The following is a description of a gene set: Genes down-regulated in peripheral blood mononucleocytes by HGF compared to those regulated by CSF2RB (GM-CSF) and IL4. Several hematopoietic growth factors, including interleukin-10 (IL-10) and transforming growth factor-beta1 (TGF-beta1), promote the differentiation of tolerogenic dendritic cells (DCs). Hepatocyte growth factor (HGF) is a pleiotropic cytokine whose effects on human DC differentiation and function have not been investigated. Monocytes cultured with HGF (HGFMo) differentiated into accessory cells with DC-like morphology, released low amounts of IL-12p70 and up-regulated IL-10 both at the mRNA and at the protein level. Upon activation with HGFMo, allogeneic CD4+CD25- T cells expressed the T regulatory (Treg)-associated transcription factor FoxP3, proliferated poorly, and released high levels of IL-10. Interestingly, blockade of surface immunoglobulin-like transcript 3 (ILT3) on HGFMo or neutralization of secreted IL-10 translated into partial restoration of T-cell proliferation. Secondary stimulation of HGFMo-primed CD4+ T cells with immunogenic DCs differentiated with granulocyte-macrophage colony-stimulating factor (GM-CSF) and IL-4 from monocytes of the same donor resulted in measurable T-cell proliferation. HGFMo-primed CD4+ T cells significantly inhibited the proliferation of naive CD4+CD25- T cells in a cell-contact-dependent manner. Finally, DNA microarray analysis revealed a unique gene-expression profile of HGF-activated monocytes. Collectively, our findings point to a novel role for HGF in the regulation of monocyte/DC functions that might be exploited therapeutically. studied in species Homo sapiens from publication Rutella S, Bonanno G, Procoli A, Mariotti A, de Ritis DG, Curti A, Danese S, Pessina G, Pandolfi S, Natoni F, Di Febo A, Scambia G, Manfredini R, Salati S, Ferrari S, Pierelli L, Leone G, Lemoli RM (PMID 16527888) Human Gene Set: RUTELLA_RESPONSE_TO_HGF_VS_CSF2RB_AND_IL4_DN, and this is the list of marker genes: FCHSD2, PPP1R16B (NCBI Gene Id 26051), GLS, ACSL3, TRIP10, NCOA3, TBC1D13, TMEM131L, IL6ST, CCL22, PKNOX1, EGLN3, ANP32A, LMBR1L, MCM5, CRYZ, SUZ12, CD1B, CASP3, ZHX2, LRRK1, IER5 (NCBI Gene Id 51278), PLXNA1, BATF3, FNBP1, PTP4A3 (protein tyrosine phosphatase 4A3), NIT2, ZNF274, HOMER2, ADAM19, QPRT, FOXJ2, TRAF1, MICAL1, SERPINF1, CFP, KIF2A, NME3, NREP, SPINT2, CCL13, LDLR, TIA1, MAOA, LYPD3 (NCBI Gene Id 94931), HEBP2, ST3GAL6, CD59, GPR137B, ITGA4, SLC1A2, CSNK1E, ST8SIA1, CYTH1, NDE1, CCSER2 (coiled-coil serine rich protein 2), CCR7, RUNX3, ARGLU1, CYB5A, ATRX, SYF2, REPIN1, RNF138, NETO2, DUSP5, MAP3K6, ANXA2P2, C3orf18, ATP1B3, RNASE4, YWHAQ, ZFAND5, RAB38, ADAM8, FSCN1, RAB11FIP1, MOB1A, CCNL1, RPL22, SDC4, DIPK1A, SCN11A, MAP3K14, TNFAIP8, VDR, CD209, ARL6IP5 (ADP ribosylation factor like GTPase 6 interacting protein 5), LY75, IL1R1, CCNG2, IL1R2, CD58, PVR, SPRED2, HDAC2, MED14, GABBR1, HERPUD1, ANXA2, RFTN1, NET1 (NCBI Gene Id 10276, neuroepithelial cell transforming 1), RABGAP1, CXCR4, BCOR, CD83, CD80, F2RL1, JAG1, TCF3, SQLE, LTB4R, TBCB, NRG1, WNT5B, DHCR7, RPS4XP2, STK17B, PLPP1, MS4A6A, ELL3, CCNI, RASGRP2, MGLL, MREG, SYNGR3, PSD3, GFPT1, DUOX1, LMNB1, POGLUT1, ROBO1, NEK3 (NIMA related kinase 3), ADAM12, IRF4, IL13RA1, SETD1B, CDKN1A, EPB41L2, CEP350, TXN (thioredoxin), IL21R, PLAC8, INHBA, MMP12, CD1E, SFPQ, SON, ARHGAP22, ENSA, CSF2RA, TBC1D4, NIBAN1, SLC16A5 (solute carrier family 16 member 5), ZNF185, SMARCC1, DPYSL2, VCAN, TNIP2, RO60, ASMTL (acetylserotonin O-methyltransferase like), SGPL1, ICAM3 (NCBI Gene Id 3385), MIS18BP1, CLIC2, CCL17, SPOCK1, FCER1A, UBAP2L (NCBI Gene Id 9898), DEPTOR, IFITM3P7 (IFITM3 pseudogene 7), CEP83, SMS, SNHG32, SLAMF1, TRADD, GADD45B, PLEKHA5, NECTIN2, DNAJB6, TUBA1C, FKBP1B, CREBL2, RAMP1, CD86, DYNC1LI1 (dynein cytoplasmic 1 light intermediate chain 1), CREG1, CD84, TTN, TRAF5, HNRNPA1, ABCG1, MARCKSL1, CERS6, OPTN, MAP4K4, CFLAR, LITAF, CEP15, FZD5 (NCBI Gene Id 81561), ZFP36, NFATC2IP, BTG1, RASGRP3, PELI1, SEPHS1, CACNA2D3, TMEM97, SORL1, GRK3, MARCKS, MED13L, TNFRSF4, EBI3, PLGRKT, RUNX1, GRSF1, RGS2, RPL28, LPP, PPM1F, PHYH, MCL1, CCL19, EED, ARHGEF6, RAB8B, BET1, BIRC3, PSEN2, LAMP3, NR4A3, JAK1, PPP1R12A, N4BP1, CRIP1, HSPB1, CSRP1, ZDHHC18, RAB9A, CIRBP, DAPP1, NKTR, RAB3GAP1, CELF2, FILIP1L, TFG, NARF, GAS6, MAP4K1